Given this list of marker genes ZNF559-ZNF177, STARD3NL, IBA57, IL1RAP, PPP2R5A, UNC5D, ZNF354C, FAM227A, DMRT2, FAR2, ZCCHC3, SLC7A2, NXPE3, SOWAHA, TRIM10, TYR, EDEM3, TAFA1, RNF138, ADH6, LMCD1, KCTD18 (NCBI Gene Id 285170), AAK1 (AP2 associated kinase 1), TMEM260, ASCC1, SERTM1, THUMPD2, IRX3, NFATC4, CEP57L1, CDC42SE2, CARS1, TMEM8B, CCNG2, PRICKLE2, NR3C1, ATXN1L (ataxin 1 like), ELAC2, MAPK6, PGM1 (phosphoglucomutase 1), TRIB1, ZSWIM6 (NCBI Gene Id 57688), ARID1A, ZMAT4, PIGG (NCBI Gene Id 54872), PTGFRN, PCDH17, KIAA0232, VPS37A, ORAI2, IL1RL1, CERS6, SLC19A3, KCNJ6, F2R, SCP2, MFSD14A, NHS, FOXI1 (forkhead box I1), FZD3, FAM120A, HTR2C, PNPLA3 (patatin like phospholipase domain containing 3), STARD13, MAP3K9, PLPBP, THRB, GPR158, DKC1, RRP7A, ZER1, NLK, KIAA0586, ZFP91, HLTF, MAP6D1, BMS1, CACNG8, GBP7, COPS7B, ZNF177 (zinc finger protein 177), PAGR1, NALF2, STT3B, DNAJA3 (DnaJ heat shock protein family (Hsp40) member A3), KLK11, APBA1, SCAF8, PARD3B, CNN3, CREM, NRN1, NOTCH2, DNAI4, PDE3A, CENPK, ABCA9, C17orf107, CALHM4, FRMD5, CD109, TDRD15, USP50, MED6, CHM, HMGCS1, VPS33B, SMIM19, ZMYM3, ANAPC16, ITGB3, ZNF596, here is a description of the gene set: Human Gene Set: MIR1304_3P Genes predicted to be targets of miRBase v22 microRNA hsa-miR-1304-3p in miRDB v6.0 with MirTarget v4 prediction scores > 80 (high confidence targets). from publication Chen Y, Wang X (PMID 31504780) species: Homo sapiens